The following is a description of a gene set: Human Gene Set: GSE20366_EX_VIVO_VS_HOMEOSTATIC_CONVERSION_NAIVE_CD4_TCELL_UP species: Homo sapiens Genes up-regulated in comparison of TconvLP versus Homeo Foxp3- (see Table 1S in the paper for details). Regulatory T (Treg) cells that express the FoxP3 transcription factor are essential for lymphoid homeostasis and immune tolerance to self. Other non-immunological functions of Treg cells, such as controlling metabolic function in adipose tissue, are also emerging. Treg cells originate primarily in the thymus, but can also be elicited from conventional T cells by in vivo exposure to low-dose antigen or homeostatic expansion, or by activation in the presence of TGFβ in vitro. Treg cells are characterized by a distinct transcriptional signature controlled in part, but not solely, by FoxP3. For a better perspective on transcriptional control in Treg cells, we compared gene expression profiles of a broad panel of Treg cells from various origins or anatomical locations. Treg cells generated by different means form different sub-phenotypes identifiable by particular combinations of transcripts, none of which fully encompass the entire Treg signature. Molecules involved in Treg effector function, chemokine receptors, and the transcription factors that control them are differentially represented in these subphenotypes. Treg cells from the gut proved dissimilar to cells elicited by exposure to TGFβ, but instead they resembled a CD103+Klrg1+ subphenotype preferentially generated in response to lymphopenia. from publication Feuerer M, Hill JA, Kretschmer K, von Boehmer H, Mathis D, Benoist C (PMID 20231436), and this is the list of marker genes: TAS1R3, FSD2, ANKRD11, ACP3, ZUP1, SRSF11, ZNF330, IL17A, SLC35F2, TRMT1 (tRNA methyltransferase 1), REXO5, ANXA7, DNAJC13, SFSWAP, PAPOLG, DNMT3B, TAF4, CD200R1L, KCTD9, TAF1C, SQLE, CALML3, CSNK1A1, TASP1, TAOK2, CRBN, DUBR, BCLAF3, ENG, TBCE, SLC28A2, TTC7A, ZBTB25, POLR3A, ITGA1, NUP155, HOPX, SFXN2, TMIE, FLCN, RAB6B, C11orf16 (NCBI Gene Id 56673), DOCK11, IL17RE, ABI3, TUBGCP4, IGFBP3, RNASE4, PIK3IP1, SLC16A6, P2RX7, CYP1B1, SETDB2, INPP1, HIC1, PRXL2C, TTC27 (tetratricopeptide repeat domain 27), SLC9A1, HOMER1, OVGP1, EPS8L1, ANKIB1, CYSLTR2, ERCC6L2, ZMYM5, MALT1, TRIM24 (NCBI Gene Id 8805), GGA3, LRP1B, CHD2, SLAMF1, HECTD3, TCAIM, GCC2, BRD8 (NCBI Gene Id 10902), PARP6, TMEM140, GIN1, MLH1, FHIP1B, CCR5, GPR183, CD160, BRIX1, ST7L, RINL, MYCBP2, CABLES1, ITGA6, MAT2A, IPCEF1, KCTD17, NOS3, KLC1, RPA1, AP4E1, CCDC62, RECQL, PPP3CB, GABBR1, FDFT1, SAMD9L, TDP2, CBX7, GTF3C2, SPG11, ABCC5, CPM, ST6GALNAC3, PTPRE, TEX10, TEC, RBM18, PER3, CPSF1, CDK10, FAM78A, XPNPEP3, ZSCAN12, VEZF1, RIMKLA (NCBI Gene Id 284716), PPP6R1, PISD, GBP6, IL4R, SBSN, SLC35F6, RNF4, MOSMO, LGALS8, TSR2, CLK1, ANKFY1, ICE2, NOCT, H1-4, DCAF8, TGFBR1, PDE5A, SEC61A2, EML5, OGA, RBM4, MTIF2, TUBGCP3, ARHGAP12, SLC1A5, GLCCI1, PDK1 (pyruvate dehydrogenase kinase 1), CFAP141, ZNF790, CD38, XKRX, ZDHHC20, OSBPL3, EFL1, RBAK, REXO4, ADAMTS6, NKRF, PDE11A, DCAF17, ABTB3, IL12RB1, HERPUD1, KIAA1191, PARP3, ATF6, PGGT1B, RSAD1, FKBP15, USP10, CPN1, ME2, SRGAP2, H2AB2, TMEM170B, INPP5B, ERAP1 (NCBI Gene Id 51752), CDADC1, CHD1L, GAK, TRIP4, SOAT2, LATS1, VPS41, CRTC2, GDPD3, FAM162B, KLHDC1, ZNF566, PKD1, CYP2D6, ZNF180, GFI1, RUNDC3B, MSMO1, HNRNPA2B1 (heterogeneous nuclear ribonucleoprotein A2/B1), ARHGAP39, AHRR